Given this list of marker genes Rab27a, Fntb, Zfp503, Atp6v0c, Tmem65, Col18a1, Tet2, Tgfbr2, Gcg, Itga9, Etv5, Hyal1, 1600012H06Rik, Abt1, Zfp711, Il21, Pitpna, Itgb1, Cep41, Lrrc28, Atp23, Zmat5, Cul5, Slc37a3, Ccr3, Sppl2c, Bin3, Cyp2c23, Gapt, Fam120b, Ophn1, Tspan18, Cacna1b, Plxnc1, Tsku, Apmap, Slc25a5, Odr4, Rfc5, Atrnl1, Ric8a, Thbs2, Gpr146, H6pd, Itgb8, Habp4, Pdcd7, Vezf1, Ttbk2, Cdh9, Myb, Slc6a16, Cdc40, Adam22, Zdhhc21, Fam168a, Cidea, Nf2, Vezt, Ppp1r7, Prdx1, Zdhhc9 (zinc finger, DHHC domain containing 9), Cps1, C130050O18Rik, Mbnl1, Antxr1, Ccdc127, here is a description of the gene set: species: Mus musculus Genes predicted to be targets of miRBase v22 microRNA mmu_miR_134_5p in miRDB v6.0 with MirTarget v4 prediction scores > 80 (high confidence targets). from publication Chen Y, Wang X (PMID 31504780) Mouse Gene Set: MIR_134_5P